The following is a description of a gene set: studied in species Homo sapiens Human Gene Set: KEGG_MEDICUS_VARIANT_MUTATION_INACTIVATED_ATP2B3_TO_ANGIOTENSIN_ALDOSTERONE_SIGNALING_PATHWAY Mutation-inactivated ATP2B3 to angiotensin-aldosterone signaling pathway. Pathway ID: N00305. Pathway type: Variant. Pathway class: nt06316 Renin-angiotensin-aldosterone signaling. Pathway Definition from KEGG: ATP2B3* -> Ca2+ -> CALM -> CAMK -> CREB => CYP11B2 -> Aldosterone, and this is the list of marker genes: ATF6B, ATF2, CAMK2A, ATF4, CAMK1D, CAMK4, ATP2B3, CAMK2B, CALM1, CREB3L3, CALM3, CYP11B2 (cytochrome P450 family 11 subfamily B member 2), CREB3L1, CAMK2D, CALM2, CREB3L4, CAMK1G, CAMK1, CREB1, CREB3L2, CREB3, CREB5, CAMK2G